The following is a description of a gene set: studied in species Homo sapiens from publication Hay SB, Ferchen K, Chetal K, Grimes HL, Salomonis N (PMID 30243574) Human Gene Set: HAY_BONE_MARROW_EOSINOPHIL, and this is the list of marker genes: TMEM160, RPN1, H2AJ, SUB1, NDUFA3, MT-CO3, GNB1, KBTBD11, MRPL23, RFLNB, KIF22, HNRNPD, MT-ATP6, MT-CO2 (mitochondrially encoded cytochrome c oxidase II), RNASE2, NDUFS6, TMX4, HSPA5, RPLP1, P2RY2, MS4A4A, BLOC1S1, MRPL33, MT-ND5, CEBPA, IQGAP3, NT5DC2, H1-10, MT-ND4, DBI, MT-ND4L (NCBI Gene Id 4539), SERPINB10, PRLR, LGALS1, WDFY2, RECK, H1-4, SNHG25, LYZ, TPM3, NDUFB11, MZT2B, MT-ND1, SERPINB8, ATP8B4, KIAA0930, PHPT1, ALYREF, SLC44A1, ANKRD13D, TMBIM6, ASRGL1, RAB32 (NCBI Gene Id 10981), RNASE2CP (NCBI Gene Id 650648), RETN, MBD3, MT-CYB, IL1RAP, COX8A